Given this list of marker genes Snw1, Tacc1, Rxrb, Nr1h3 (NCBI Gene Id 99182), Nr1h4, Asxl1 (ASXL transcriptional regulator 1), Arid5a, Med1, Nrip1, Hmga1, Sumo2, Ncor2, Fus, Ncoa2, Nsd1, Uimc1, Ncoa6, Hmga1b, Med25, Ctbp2, Lrif1, Nr1h2, Pramel13, Ncor1, Cnot1, Ncoa1, Rarg (retinoic acid receptor, gamma), Pparg, Rxra, Vdr, Nr0b2 (NCBI Gene Id 23957), Actn4, Prmt2, Rarb, here is a description of the gene set: species: Mus musculus Binding to a nuclear retinoic acid receptor, a ligand-regulated transcription factor belonging to the nuclear receptor superfamily. Mouse Gene Set: GOMF_NUCLEAR_RETINOIC_ACID_RECEPTOR_BINDING